The following is a description of a gene set: species: Mus musculus Binding to a macromolecular complex. Mouse Gene Set: GOMF_PROTEIN_CONTAINING_COMPLEX_BINDING, and this is the list of marker genes: Ptprn, Pik3r5, Dbn1, Mthfr, Frrs1l (ferric-chelate reductase 1 like), Ighg1, Gas7, Dclre1b, Eif1, Anxa6, H2-Q2, Ube2srt, Exoc4, Abi3bp, Dhx9, Rpsa, Mff, Ifna12, Vcl, Ube2s, Ppp3cb, Cdh17 (NCBI Gene Id 56487), Gnb4, Myh15, Neb (nebulin), Nsf, Myo10, Actn2, Kif3a (NCBI Gene Id 192824), Cbx5, Snx3, Prkaa1, Wdr45b, Ibsp, Naa10, Nptxr, Prpf6, Ift56, Wmp, Rpl35rt, Ddx5, Pira13, Ap1ar, Mptx2, Pdgfra (NCBI Gene Id 231312), Adam26a, Marcks, Esm1, Hspa4, Mcur1, St13, Stoml2, Elk1, Slc34a1, Pcolce2, Kif3b, Iqgap2 (IQ motif containing GTPase activating protein 2), Ing2, Hadhb, Kcnh5, Syne3, Snrpd3, Ifna4, Unk, Arpc2 (actin related protein 2/3 complex, subunit 2), Gas2l2, Cebpe, Itgb2, Itgb5, Kcnma1 (NCBI Gene Id 70528), Tmco1, Ifnk, Ceacam1, Apba1, Snrpg, Sh2b3, Pdp1, Itga5, Jam2, Ppp1r9a, Gad2, Capza3, Ache, Chm, Git1, Pcsk9, Mttp, Strn, Hk1, Adgrg1, Skap1, Prkn, Letmd1, Mtres1, Amigo3, Gp5, Mta3, Hgf, Vdac1, Atp5po, Ung, Bckdha, Ruvbl1, Eif3k, Fcer1g, Ifne, Dock2, Gnasas1, Plk2 (NCBI Gene Id 20620), Myo1e (NCBI Gene Id 71602), Snd1, Usp14, Insr, Pms2, Mcrip2, Uqcrfs1, Kif5b, H1f4, Tgfbr1, Rpain, H2-Q4, Mmp13, Homer1, Sesn2, Plec, Itgb6, Mptx1, Myo5b, Pym1, P2rx1, Ephb1, Appl2, Atp5pf, Atm, Nfkbia, Ppih, Ablim1, Eno1, Lrp8, Derl2, Itgav, Bop1 (NCBI Gene Id 97992), Gclc, Cel, Ajap1, Spta1, Marf1, C1qtnf1, Tg, Mutyh, Armh4, Plk1, Pten, Eif5a2, H2-M10.1, Gnai1, Eps8l1, Calr, Lsr, Gnaq, Gfap (glial fibrillary acidic protein), Cfap100, Bag4, Rps2, Gli3, Eif6, Gucy1a2, Ptpn2, Ndufab1, Clnk (NCBI Gene Id 27278), Coro1b, Vtn, Ift70a2, Bmt2, Usp16, Tpm4, Grb2, Ltc4s, H2-Aa, Sparcl1, Eps8l2, Dhx33, Ppp2ca, Pcna, Gsk3b, Ms4a1, Twf2, Nomo1, Homer2, Gria2, Ttr, Ush1c, Chmp6, Bhmt1b, Ifna2 (interferon alpha 2), App, Crp, Uba3, Bok, Eef2, Cnga4, Stab2, Jmjd6, H2-Eb2, Ank2, Abl1, Bak1, Gm13277, Dnajc1, Itga1, Adora1, Spp1, Gmfg, Eefsec, Nvl, Rbpj, Itgax, Drd2 (NCBI Gene Id 13489), Lrp12, Vapa, Sptbn4, Lgals8, Usf2, Shc1, Sec61g-ps2, Git2, Ldlr, Fcer1a, Dync1i2, Maip1, Chrna4, Hmbox1, H2-D1, Msr1, Tssk4, Tpm3-rs7, Capzb, Actr3, Egfr, Cdc20, Podn, Ptprf, Parva, Clic4, Mdm2, Lox (lysyl oxidase), Hspa5, Eif4a3l2 (eukaryotic translation initiation factor 4A3 like 2, NCBI Gene Id 434080), Flna, H1f8, Psmc3ip, Ngfr, Dnajb2, Mafb, Ppp4c, Birc3, Mlh1, Coro2a, Afdn, Igf1r, Taf7, Psmd14, Klrd1, Nfyb, Tgfbi, Flt3, Zfp36, Ublcp1, Cd36, Glyr1, Bmp2k (BMP2 inducible kinase), Myh6, Sptan1, Nemf, Csnk2b, Itga11, Agap2, Rims2, Ager, Tagln3 (transgelin 3), Dmtn, Stx1a, Itga8, Gna12, Kcnab2, Aldoc, Ctsl (cathepsin L), Cfl1, Arpc4, Rap1b (RAS related protein 1b), Lrpprc, Ltn1, Map3k13, Ambp, Nphs1, Dmd (NCBI Gene Id 93863), Ush2a (usherin), Zfp598, Zc3h18, Ola1, Eif4b, Tspan4, Naa15, Fmnl1, Wfs1, Cog2, Grin2a, Upf1, Sqstm1 (NCBI Gene Id 18412), Pink1, Ythdf1, Eif1b, H1f6, Rad23a, Inhba (inhibin beta-A), Shroom3, Neil3, Tmem223, Cpeb2, Msh6, Ttn, Cpd, Golga2, H2-Q1, Tap2, Grip1, Itga2b (integrin alpha 2b), Rptor, Myh13, Cetn2, Tgfb2, Stxbp3, Rpl35, Kcnh1, Ptk2, Dbnl, Hnrnpc, Nr1h3, Pex1, Apc, Sec61g, Bcl2l1, Pdgfa, Phpt1, Acvr2b, Gfra1, Slfn1, Mtif3, Srebf1, Kash5, Camsap1, Crebbp, Acvr2a, Krt19, Ighg2c, Mlkl, Rell2, Cps1 (carbamoyl-phosphate synthetase 1), Rcc1, Pirb, Adora2a, Bcap31, Sf3b3, Limd2, Mapt, Cd2bp2, Tnfrsf1a, Snrpd1, Ablim3, Skil, Chrna3, Fyb1, Itga4, Shroom1, Esr1, Pi4k2a, Hnf4a, Sdcbp, Ccn6, Rpn2, Grin2b, Terf2, Fcer2a, Arhgap35 (Rho GTPase activating protein 35), Cebpg, Six2, Eri1, Ifna11, Aif1l, H1f1, Snrpe, Cdk4, Zfp423, Edf1, Epb41l2 (erythrocyte membrane protein band 4.1 like 2), Dspp, Rnf185, Ifna16, Katna1, Ajuba, Mfge8, Ssrp1, Itga3, Nup58, Jup, Tpr, Acvr1c, Dctn6, Gbp2b (NCBI Gene Id 677276), Fcgr2b, Irs1, Smad7, Map2k1 (mitogen-activated protein kinase kinase 1), Myo3a, C4b, Tmem201, Vps16, Gabrb3, Ptprz1, Tpm2, Prickle1, Nrxn1, H2-K1, Sec61b, Fgfr1, Brk1, Prr7, Coro1c, Dapl1, Nisch, Nacc2, C4a, Ppp1ca, Cav3, Itgal, H1f2, H2-M10.6, Col4a3, Fos, Ripk3, Itga10, Traf2, Macf1, Ccnb1, Cdk5r1, Sin3a, Shfl, Pim1, Itgb1, Madcam1, Ifna13, Itch, H3f5, Epb41, Carmil1, Nefm, Prkag1, Pls1, Frmd5, Sptb, Srgn, H1f5, Ifna6, Ctnna2, Dst, Nasp, Atp5if1, Dstn, Lilrb4a, Pdx1, Lrrn3, Kctd5, Nod2, Mmp3, Itgb8, Dctn2, Rplp2, Lrrk2, Lima1, Npas4, Fmr1, Med24, Crb2, Oxa1l, Ppia, Mllt10, Hes1, Nras, Sparc, Bax, Xpo5, Gjb6, Mcl1, Myo5c, Coro2b, Psmg3, Snx9, Tsn, Ctnna3, Gucy1b1, Tnc, Hexim1, Gnb3, Ccn1, Cd8a, Ccbe1, Tpm3, Camsap2 (calmodulin regulated spectrin-associated protein family, member 2), Atp5f1d, Ighmbp2, Gucy1a1, Tmem131 (NCBI Gene Id 80568), Fgf2, Cnga3, Vill, Ugt1a6a, Atp5pb, Slfn14, Krt8, Ezh2, Pls3, Kifap3, Ift70a1, Fgf1, Rbm3, Cenpf (NCBI Gene Id 98315), Cetn4, Lamb2 (laminin, beta 2), Hexb, Wdr47, Lilra6, Atr, Myc, Lyn (LYN proto-oncogene, Src family tyrosine kinase), Malsu1, Ctnnb1, Cryab (crystallin, alpha B), Tmed10, Syp, Suclg1, Jam3, Ptx3, Spata33, Myh7b, Comp, Hadha, Bcl2l2, Itga6, Tulp1, Fst, Prkar2a (protein kinase, cAMP dependent regulatory, type II alpha), Lasp1, Shank1 (SH3 and multiple ankyrin repeat domains 1), Syne1, Ddr2, C8b, Scp2, Nr3c1, Cabin1, Lrrc15, Actr2, Ripk1, Eif1a, Ybx3, Vps33b, Mcm9, Fas (NCBI Gene Id 14102), C8g, Pex26, Arpc3, Prph, Cnga2, Mmp12, Cdk2, Ogt, Apbb1, Secisbp2, Uqcc5, Svil (supervillin), Lum, Tspan8 (NCBI Gene Id 97634), Rxra, Tsix, Prmt7, Gm13283, Ank3, Col6a4, Nefh, Bckdhb, Nck2, Prkaca, Pdia4, Cd1d1, Max, H2-M10.2, Cetn1, Ufd1, Tmem147, Ecm2, Cetn3, M6pr, Adam18, Chadl, Mprip, Gpnmb, Vipas39, Nr0b2, Fhod1, Myh7 (myosin, heavy polypeptide 7, cardiac muscle, beta), Fcho1 (FCH domain only 1), Arid1b, Gna14, Pgam5, Pttg1, Dzip1, Rxrb, Cript, Cngb3, Itgb3, Myo19, Sptbn5, Myh14, Ephb2, Atp5me, Kbtbd13, Lipc, Pafah1b3, Pqbp1, Gnai3, Megf10, Nog, Nup62, Fermt2, Nherf1, Ppp2r2a, Tshr, Thy1, Myh2, Rasa1, P3h4, Eif5a, Col6a2, Ncoa1, Alox5ap, Gtpbp6, L3mbtl1, Casp3, Bcl2a1d, H3f3b, Sacs, Met, Psmb9, Ldlrap1, Napa, Telo2, Igbp1, C1qbp, Pdk1, Lztfl1, Aebp1, Prkcz, Plcb2, Ddr1, Clasp2, Wdr1, Cdk5rap3, Gabrr1, Hdac6, Cxcl12, Fermt1, Kcnip2, Col3a1, Sbds, Ank1, Ciita, Atmin, Eno2, Rnf135, Sidt2, H2-Q6, Fcgr1, Tgfb3 (transforming growth factor, beta 3), Slc4a1, Rras, Capns1, Nop58, Arpc5l, Capza2, Rab11fip3, Capza1 (NCBI Gene Id 12340), Rps21, Tbc1d5, Klrc2, Vwf, Gnb1, Prmt5, Kcnip1, Phf6, Ikbkb, Smad4, Eif4a3l1, Camsap3, Nr1h4, Bcl2a1b, Dnm2, Myo18a, Sec61a2, Rs1, Angptl3, Icam5, Mif, Map1s, Arpc1a, Rad50, Epop, Capn2, Pon1, Abcf1, Fbln5 (NCBI Gene Id 23876), Fcgr4, Sharpin, Stab1, Tulp2, Jmy, Adm2, Iqgap1, Erc2 (ELKS/RAB6-interacting/CAST family member 2), Syde1, Fmnl2, Ntsr2, Ccne1, H2-DMb2, Fmnl3, Hras, Flii, Lama5 (NCBI Gene Id 99115), Calca, Rapgef4, Katnb1, Mtif2, Ran, Xrcc5, Kcnh7 (NCBI Gene Id 352971), Serbp1, Uchl5, Vcp, Itga2, Strap, Bag3, Apcs, Gmfb, Hbb-y, Dpp4, Cntf, Itgam, Myo1c, H1f3, Snrnp70, Eloc, Npnt, Adcy4 (NCBI Gene Id 11510), Tub, Cd74, Ifna15, H1f9, Mbtd1, Fcgrt, Rnf168 (ring finger protein 168), Slc27a5, Rbm39, Ndufa8, Eif3c, Lgals3, Ctsh, Tfpt, Mfap2, Sorl1, Thra, Vps4a, Rtn4, Vil1, Ocm, Tll1, Ncoa2, Fermt3, Naa16, Ddx39b, Chrna5, Adam8, Hif1a, Jdp2, Atp5f1e, Gnat2, Txn2, Myh1, Myo1d, Mlc1, Brd4 (NCBI Gene Id 57261), Rela, Vinac1, Fbln1, Fbxw11, H2-M2, Cd40lg, Sipa1l1, Vldlr, Helb, Iqgap3, Mtrfr, Muc4, Nlgn1, Acvrl1, Vamp2, Syk, Arrb2, Cd177, H2-Q7, Pknox2, Uqcrc2, Derl1, Ctnnal1, Clspn, Pira2, Hnrnpab, Cpsf6, Ercc8, Piwil1 (piwi-like RNA-mediated gene silencing 1), Ybx2, Ep300, Dcn, Frg1, Myh9, Gad1, Nrap, Csnk2a1, Igf2, Garre1, Amotl2, Cgas, Cav1, Sag, Tssk6, Xpc, Bltp3b, Hspg2, H2az1, Aldh1l1, Anxa7, Tssc4, H1f0, Ercc4, Raf1, Aif1, Gch1, Ap2b1, Mrps27, Tma16, Itgb1bp1, Ina, Gemin5, Cdh26, Ablim2, Fcmr, Hip1, Cngb1, Ntsr1, Mrrf, Gas2l3, Atf1, Tgfb1, Csde1, Kif5a, Cnga1, Ip6k2, Mettl17, Nckipsd, Cfl2, Lcp1, Ap2a1, Rplp1rt, Adcy2, Ppp1r9b, Fscn1 (NCBI Gene Id 14086), Strada, Ptcd3, Pltp, Ifna7, Myo1h, Tnr, Gbp2, Hp1bp3, Myh4, Sec61bl (SEC61 translocon subunit beta like), Nolc1, Lonrf2, Arpc1b, Cdh5, Mmp9, Ighg3, Ckap5, Acvr1b, Nrg1, Inca1, Nuf2, Snrpc, Ifnab (interferon alpha B), Abcc9, Ubd, Cd9, Cftr, Oaz1, Dhx29, Pxn, Smarca4, Hmgb1, Prmt1, Flnb, Itprid2 (ITPR interacting domain containing 2), Plpp3, Adrb2, Parp1, Cflar, Hnrnpk, Actn3 (actinin alpha 3), Stau2, Ppfia2, Tlr2, Gtf2f1, Apoe, Ubac1, Amfr, Wasf1, Myl4, Myo9b, Zfp593, Ncoa3, Icam1, Xrcc6, Id1 (inhibitor of DNA binding 1, HLH protein), Fap, Cdkn1c, Cxadr, Sap30l, Hr, Svep1, Hspd1, H2-Q10, Mcts1, Slfn4, Ppp1r42, Espnl, Akap5, Phax, Mb21d2, Bik (NCBI Gene Id 12124), Mllt6, Rnasel, Uchl1, Noc2l, Rpl23a, Mtor, Vcam1, Nipbl (NIPBL cohesin loading factor), Spock2, Gtsf2, Add1, Fscn2, Itgb7, Pafah1b1, Alad, Slc6a4, Ercc1 (NCBI Gene Id 13870), Il12b, H2-M11, Fbxo5, H2-Eb1, Gm13271, Ush1g (NCBI Gene Id 217309), Amph, Smad3, Misp, Dab2ip, Itpr3, Gm13272, Acvr1, Fgd4, Timp2, Cdca5, Gucy2e, Hba-a1, Tsnax, Tpm1, Nfkb1, Park7, Cdh13, Prkaa2, Ctnna1, Gemin4, Tubb5, Sgta (NCBI Gene Id 68091), Erbb2, Rad23b, Fzd4, Bin1 (bridging integrator 1), Gria1, Acd, Snrpn, Cib2, Synj1, Arrb1 (NCBI Gene Id 74110), Gnb2, Clu (clusterin), Htr2a, Gpihbp1, Flnc, Pwwp2a, Adam15, Kdr, Lck, Serpinh1, Ezr, Secisbp2l, Slf2, Uqcrh, Anxa8, Ncor2, Trpv4, Emp2, Prmt2, mt-Cytb, Strn4, Apoa2, Hmga2, Hcls1, Ndel1, Wiz, Tnks1bp1, Pros1, Fcamr, Pof1b, Nid1, Hbb-bs, Elob, Caly, Myh3, Adam17, Kat6b, Shtn1, Eed, Ywhab, Drd1, Kcne1, Pdgfb, Zfp827, Eif2s1, Clta, Pcolce, Atp6v0d1, Zc3h12a, Ift70b, Ugt1a6b, Spata2, Dync1i1, Bcl10, Nup54, Panx2 (pannexin 2), Ndufab1-ps (NADH:ubiquinone oxidoreductase subunit AB1b), Thbs4, P2rx2, Tulp3, Arnt2, Ptn, Myo18b, Appl1, Myh8, Ythdf3, Gpsm2, Pinx1, Efl1 (elongation factor like GTPase 1), Gga3, Sptbn2, H2-DMa, Snrpa, H2-M10.3, Dynll2, Itgb1bp2, H2-M1, Myo16, Vhl, Gp6, Cdc20b, Supt6, Letm2, Rps3, Ap2a2, Znhit1, Rplp1, Tnnt2, Srp54a, Cdk7, Psmg1, Aak1, Cd93 (CD93 antigen), Cnn1, Spock3, Chrnb4, Slc25a3, Unc13a (NCBI Gene Id 73695), Pdzk1, Med1, Cask, Arid1a, Dnai3, Selp, Ppp1cc, Depdc5, Marcksl1, F2r, Cd2ap, Fcgr3, Antxr1, Ccn5 (cellular communication network factor 5), Nexn, Ttc5, Tsc2, Slc6a3, Xist, Rplp2-ps1, Klhl17, Ulk1, Arnt, Cd4, Actr3b, Ctbp2, Ahr, Fbl, Sec61a1, Flcn, Lrp2, Ptpra, Sptbn1, Usf1, Cnn3, Gnat3, Habp4, Usp13, Poldip3 (NCBI Gene Id 97955), Lin37, Prnp, Cdkn1a (cyclin dependent kinase inhibitor 1A), Gucy2f, Slc26a5, Mtss1, Macroh2a1, Ifih1, Ccnd1 (NCBI Gene Id 12443), Srpra, Hmgn3, Rarb, Amer1, Myo1b, Tap1, Whamm, Cx3cl1, Ms4a2, Gnaz, Cd81, Psmg4, Panx1 (NCBI Gene Id 55991), Otof, H2-M5, Umod, Dag1, Dnm1l, Myo5a, Taco1, Cpeb3, H2-T23, Supt16, Fadd, Myo1f, Gas2l1, Rac1, Kcnd2, Tcam1, Rad18, Ifna5, Dnm1, Rap1a (RAS-related protein 1a), Gpc1, Atp5pd, Top2b, C8a, Rictor, Maf, Ddx3x, Klrc1, Bcl2, Cspg4, Dnttip1, Prkcsh, Scfd1, Pwwp3a, Znhit6, Wasf2, Myh11, Apobec1 (apolipoprotein B mRNA editing enzyme, catalytic polypeptide 1), Samd1, Parp2, Iftap, Zfand1, Lrp1, Ifnb1, Pitx2, Src, Gtf2e2, Carmil2, Hmgn1, Apoa1, Ppihl, Pfkp, Dynll1, Ifna9, Pdcl, Ercc5, Braf, Kcnh6, H2-Ea, Gclm, Tagln2, S1pr2, Ighg2b, Dap (NCBI Gene Id 70940), Cdk5rap1, Itgb2l, Xirp2, Bcl2a1a, Washc2, Bmyc, Kcnh2, Map3k20, Rho, Ppp2r2b, Vps28, Adam24, Hotair, Gtsf1l, Tapbp, Map1a (microtubule-associated protein 1 A), Ywhaz, H2-Oa, Map3k1, Rbx1, Kpnb1, Add3, Gm34220, Tnxb, Tradd, Msh2 (NCBI Gene Id 17685), Mcm8, Srp68, Fzd5 (frizzled class receptor 5), Prpf31, Ctss, Smarca5, Bag6, Hnrnpu, Map1b, Ndufaf2, Opa1, Pafah1b2, Tnni3, Cdkn1b, Sall1, Rbp4, Ezh1, Nckap1l, Rcsd1, Snca, Srp19, Adss1, Luzp1, Cttn, Scarf1, Pes1, Timm50, Pira12, Ndufa4, Sall2, Nf2, Hmgn5, F11r, Lmbrd1, Gna11, Tln1, Hip1r, G3bp1, Fhod3, Tgfbr2, Gnas, Srp72, Snrpd2, Sort1, Gsn, Sema7a, F2rl1, Samd14, Ndufa9, Jun, Ctsk, Dlg4, Rack1, Dlg2, Gas2, Ttc39aos1, Cnn2, Cd226, Stx7, Fstl3, Spcs1 (signal peptidase complex subunit 1 homolog (S. cerevisiae)), Apex1, Jaml, Plp1, Dhx34, Chuk, Rc3h1, Rab29, Mrc2, Txnrd2, Chrnb2, Add2, ENSMUSG00000131459, Itga7, Abce1, Nefl (neurofilament, light polypeptide), Cir1, Inha, Tln2, Hcn2, Grin1, Ptprc, Abca1, Abi3, H2-Ab1, Ecpas, Cyfip1, Kctd2, Ccnf, Uqcrc1 (ubiquinol-cytochrome c reductase core protein 1), Arpc5, Ncln, Coch, Smarca1, Twf1 (NCBI Gene Id 19230), Ctdp1, Slc3a1, Psmf1, H2-T22, L1cam, Myo6, Becn2, Tuba1a, Ddb1, Tsg101, Nectin1, Pakap, Gna13, Det1, Tssk1, Gnai2, Ago2, Scamp5, Lca5, Myo9a, Bicd2, Cyrib, Slfn2, Actr6, Cacnb2, Lamb3, Wrn, Spock1, Larp1, Scin, Rtn4r, Kptn, Atg101 (autophagy related 101), Disc1, Scarb1, Gtpbp4, Lims1, Itga9, Il1b, Suclg2, Ccn4, Pdk2, Adra2a, Ist1, Ptch1 (patched 1), Kcnn1, Snrpb, Guf1, Numa1, Colec12, Mapk8ip2, Nploc4, Ruvbl2, Hbb-bh1, Uqcrb, Itgbl1, Ppara, Trem2, Crtap, Pip, Sirt6, Cotl1, Pgf, Cpeb1, Eno3, Ankrd54, Rab38 (NCBI Gene Id 72433), Wasf3, Thbs1, B2m, Prkca, Tnn, Xirp1, Hira, Sec61g-ps3, Adrm1b, Shank3, Ccn3, Fscn3, Ikbkg, Actn1 (NCBI Gene Id 94278), Myh10, H2-Ob, Tfrc, Ctsb, Rab7, Ihh, Wrap53, Myo7a, Slf1, Ranbp2, Ifnz, Ppp3ca, Adam9, Letm1, Ezhip, Bcl2a1c (NCBI Gene Id 12046), Bhmt, Ywhae, Pvalb, Khdrbs1, Rest, Impact, Gm13275, Tmem70, Cep131, Cd160, Mmp14, Pzp, Shroom2, Slc25a46, Eif4a3, Gnat1 (G protein subunit alpha transducin 1), Top1, Dlgap1, Myo15a, Stk11, Casr, Psme4, Epcam, Pde6g, Cd300lg, Tapbpl, Afg2b, Espn, Derl3, Dubr, Ddb2 (NCBI Gene Id 72138), Jchain, Fn1, Npm1, Trp53, Ide, Itgad, Cfap73, Eif4h, Pak1, Abitram, Fyn, Nopchap1, Col16a1, Kcnn3, Actn4, Scap, D1Pas1, H2-DMb1, Glrb, Gm13276, Hdac1, Smc3, Kat5, Avil, Tmem258, Ifna1 (interferon alpha 1), Glra1, Hmgn2, Cd151, Clmn, Ermn, H2-M10.5, Iqcb1, Smc1a, Cul2, Igf2r, Kras, Gna15, Ubxn1, Wdr12, Afg2a, Tbc1d7, Kcnq1ot1, Hbb-bt, Ccn2, H3f3a, Eno1b, Bicd1, Crhr1, Triobp, Adrm1, Cinp, Atf2 (activating transcription factor 2), Pelo, Vrk1, Itgb4, Tssk2, Adam25, Birc2, Vps4b, Tnnc1, Slc11a2, Strn3, P2rx6, Pigr, Dnaja3, Dnajc2, Itpr1, Micall2, Atp6v1b1, Fxr1, Sspn, Cdk5rap2, Igf1, Fbn1, Hsd17b12 (hydroxysteroid (17-beta) dehydrogenase 12), Adgrg6, Isg15, Hrg, Ilk, Nebl, Ccdc146, Eral1, Ptk2b, Rab32, Rph3a, Tepsin, Myo7b, Lpl, Eif2a, Tab1, Lamb1, Uhmk1, Srrt, Cdh2, H2-M10.4, Nr3c2, Tgfbr3, H2-T10, Dnaaf1, Slfn3, Pick1, Gchfr, Dab2, Ppib, Pwwp2b, Chd1l, H2-M9, Gabra6, Coro6, Capg, Ceacam2, Coro1a, Malat1, Mr1, P4hb, Cd63, Hnf1b (HNF1 homeobox B), Shroom4, H2-T3, Magi2, Nmd3, Cebpa, H1f10, Trex1, Casp8, Ccdc47, Snrpb2, Vps33a, Rnf4, Gnao1, Itgae, S1pr3, Rnf169, Zfp622, Pex6, Utrn, Smg6, Nod1, Cpeb4, Gnal, Col6a1, Rnf5, Cdc42bpb, Fzr1, Nfe2l1, Nap1l4, Ifrd2, Ppp5c, Icam2, Myo1a, Icam4, Bloc1s6, 2300002M23Rik, Ifna14, Myo1g, Fgr, Capza1b, Emilin1, Tef, Nme1